The following is a description of a gene set: To identify signature genes that help distinguish (1) sepsis from non-infectious causes of systemic inflammatory response syndrome, (2) between Gram-positive and Gram-negative sepsis. species: Homo sapiens Human Gene Set: GSE9960_HEALTHY_VS_SEPSIS_PBMC_DN from publication Payen D, Lukaszewicz AC (PMID 19535937) Genes down-regulated in peripheral blood monocytes (PMBC): healthy versus sepsis., and this is the list of marker genes: RNF138, PRKCE, CALHM1, NLRP11, HOXA1, SEPTIN7P9, ZDHHC8, NUPR1, INPP5E (NCBI Gene Id 56623), OTUB2, LINC01592, B3GNT2, GOLGA6L2, IFI27, TCF19, PPP4R3A (NCBI Gene Id 84644), C4orf36, APLNR, SAMD9L, PAPOLA-DT, XRN2, MECR (NCBI Gene Id 554211), IDO2, AFF1, PPP1R17, SPDYE1, MYO7A, OR5H1, CC2D1A, NLGN4Y, TRPM7, PGF, MAN1B1-DT, WASHC4, SEPHS2, TEKT5, ZNF862, RCBTB1, LINC00324, HLA-K, HIPK1, ZFP36, FAM78B, LINC00315, CHST4, HSPB1, MFSD6L, LRP5L, UBQLN2, VESTAR, ESX1, MBD3L2, GKAP1 (NCBI Gene Id 80318), CAPN11, ECI2-DT (NCBI Gene Id 100507506), CEP72, SPIN1, GK2, ZBTB39, LGALS12 (galectin 12), ZNF92, LINC00839, LRSAM1, GARIN2, LINC00629, ARHGAP12, TMUB2, MGARP, INCENP, WSB1, OR4C1P, LATS1, ENSG00000291101, BOLA2, ACBD5, SLC25A16, ZNF622, PLSCR4, SHOX, TENT5A, NAALADL2, GNS, HMGB1, PLEKHA2, SWAP70, RBM24, MYH16, ANKRD34C, CDH18 (cadherin 18), KCNS3, CYP1A2, C11orf96, SCD5 (stearoyl-CoA desaturase 5, NCBI Gene Id 79966), TBX19, INTS13, RASEF, LGALS8, SLC25A34, NCR2, ENSG00000291065, MAPK3, GALNTL6, HTR1D, ZNF577, OPHN1, PIWIL2, EFCAB3, MPP1, NPTX1, DNASE2, EPHB1, ZNF731P, TBCEL, TMC1, DDIT4L, CAMK2A, EGFLAM, HLA-C, PTCHD4, MYOM2, SYNJ1, BRCA1, FER, TBX5-AS1, SASS6, BLID, WAS, FILNC1, LINC00865, RBP5, KCNJ1, LARP7, NOTCH2, CDC20B, SAG, STK11, GCSAM, FCRL1, AHI1-DT, SH3BP5-AS1, F8, RBM43, ENSG00000291211, CMBL, ZNF528, CBY3, SEC24B, RMND5A (required for meiotic nuclear division 5 homolog A), MATCAP1, ZNF501, USP1, APOBEC3A, IFI16, P2RY1, KCTD4, SLC10A7, GRAPL, ANXA2R, LDB2, RSAD2, CELF1, LINC01226, IFT74, BTD, RECK, TTBK2, SLC38A4-AS1, EFNA5, RPS10P7, IL12A, SPEM1, APOBEC3B, DBH-AS1, EVA1B, ZNF471, MKNK1-AS1, KCNE2, TAT, LEP, ZPBP2, C1QTNF12, HOOK1, NAPA, ELP3, ZSCAN30, FOXP4